The following is a description of a gene set: CREB-binding protein (CBP) and its para-log p300 are transcriptional coactivators that physically or functionally interact with over 320 mammalian and viral proteins, including 36 that are essential for B cells in mice. CBP and p300 are generally considered limiting for transcription, yet their roles in adult cell lineages are largely unknown since homozygous null mutations in either gene or compound heterozygosity cause early embryonic lethality in mice. We tested the hypotheses that CBP and p300 are limiting and that each has unique properties in B cells, by using mice with Cre/LoxP conditional knockout alleles for CBP (CBP(flox)) and p300 (p300(flox)), which carry CD19(Cre) that initiates floxed gene recombination at the pro-B-cell stage. CD19(Cre)-mediated loss of CBP or p300 led to surprisingly modest deficits in B-cell numbers, whereas inactivation of both genes was not tolerated by peripheral B cells. There was a moderate decrease in B-cell receptor (BCR)-responsive gene expression in CBP or p300 homozygous null B cells, suggesting that CBP and p300 are essential for this signaling pathway that is crucial for B-cell homeostasis. These results indicate that individually CBP and p300 are partially limiting beyond the pro-B-cell stage and that other coactivators in B cells cannot replace their combined loss. Human Gene Set: XU_CREBBP_TARGETS_UP studied in species Mus musculus Genes up-regulated in pro-B lymphocytes after knockout of CREBBP. from publication Xu W, Fukuyama T, Ney PA, Wang D, Rehg J, Boyd K, van Deursen JM, Brindle PK (PMID 16424387), and this is the list of marker genes: RCN1, PROM1, LGMN, HLTF, LRG1 (leucine rich alpha-2-glycoprotein 1), RAD1, NVL, S100A6, GBP4, PPAN, MCM2, THA1P, RRP1B, HMOX1, ADSL, LDAF1, XPOT, LRRN1, NME4, PRMT1, LMBR1L, GNL3 (G protein nucleolar 3)